The following is a description of a gene set: The tumor suppressor p53 is a key modulator of the cellular stress response, inducing cell-cycle arrest, apoptosis, senescence and cell differentiation. To evaluate further the molecular mechanism underlying p53 function, the transcriptional profiles of proliferating and senescent WI-38 cells, both wild-type p53 expressers and counterparts with an inactivated p53, were compared by DNA microarray analysis. In particular, the amyloid-beta precursor-like protein 1 (APLP1) is induced in senescent cells in a p53-dependent manner. APLP1 was confirmed to be a novel transcriptional target of p53 by in vivo and in vitro characterization of a p53 responsive element found in the first intron of the APLP1 gene locus. APLP1 knockdown experiments demonstrate that APLP1 is required for the proliferation of fibroblastic and epithelial cells. Moreover, depletion of APLP1 expression diminishes stress-induced apoptosis of neural cells, whereas ectopic APLP1 expression augments apoptosis. Based on these data, a mechanism is proposed whereby p53-dependent induction of APLP1 is involved in neural cell death, and which may exacerbate neuronal cell loss in some acute or chronic neurodegenerative disorders. Genes up-regulated in WI-38 cells (senescent primary fibroblasts) after inactivation of TP53 by GSE56 polypeptide. studied in species Homo sapiens Human Gene Set: TANG_SENESCENCE_TP53_TARGETS_UP from publication Tang X, Milyavsky M, Goldfinger N, Rotter V (PMID 17533371), and this is the list of marker genes: WFDC1, ADAMTS5, ALDH3A2, RAPGEF4, A2M, ZMAT3, HBG1, HBG2, IVNS1ABP, USF2, VAMP8, SLC4A4, BACE1, GBX2, COX7A1, SIM2, CCND2, C7 (complement component 7), GABBR2, MMP3, CDKN1A, LCAT, NRG1, GMFG, TSPAN12, SNCA, PSTPIP2 (NCBI Gene Id 9078), TFAP4, ABCA8, HSD17B2 (hydroxysteroid 17-beta dehydrogenase 2), CCDC85B, CLIP1, APLP1